The following is a description of a gene set: Unilateral cleft lip species: Homo sapiens A non-midline cleft of the upper lip on one side only. Human Gene Set: HP_UNILATERAL_CLEFT_LIP, and this is the list of marker genes: SUMO1, KAT5, MID1, GDF11, KIF7, SMAD4, HYLS1, MED12, TAPT1, PTCH1